Given this list of marker genes Lipf, Slc2a5, Lct, Amy2a3, Pir, Guca2a, Pnliprp1, Amy2a2, Amy2a4 (amylase 2a4), Sis, Chit1, Pnlip (NCBI Gene Id 69060), Chia1, Alpi, Pnliprp2, here is a description of the gene set: electronically inferred by orthology from the curated human pathway studied in species Mus musculus Reactome Pathway: Digestion and absorption This event has been computationally inferred from an event that has been demonstrated in another species.<p>The inference is based on the homology mapping from PANTHER. Briefly, reactions for which all involved PhysicalEntities (in input, output and catalyst) have a mapped orthologue/paralogue (for complexes at least 75% of components must have a mapping) are inferred to the other species.